The following is a description of a gene set: studied in species Homo sapiens A defined subset of the ABC transporter superfamily, the ABCA transporters, are highly expressed in monocytes and macrophages and are regulated by cholesterol flux which may indicate their role in in chronic inflammatory diseases. Some D and G members of the ABC transporter family are also important in lipid transport (Voloshyna & Reiss 2011, Morita & Imanaka 2012, Morita et al. 2011). part of: ABC-family protein mediated transport Reactome Pathway: ABC transporters in lipid homeostasis, and this is the list of marker genes: ABCA7, APOA1, PEX19, ABCA2, ABCA6, ABCD2, ABCG5, PEX3, ABCG1, ABCA3, ABCD3, ABCA5, ABCA12, ABCA10, ABCA9, ABCD1, ABCG4, ABCG8